The following is a description of a gene set: Human Gene Set: GSE45365_HEALTHY_VS_MCMV_INFECTION_CD8_TCELL_IFNAR_KO_UP Genes up-regulated during primary acute viral infection in dendritic cells with IFNAR1 knockout: CD8A versus ITGAM+. studied in species Homo sapiens Murine Cytomegalovirus (MCMV) infection leads to early activation of various immune cells, including B and T lymphocytes, before the actual initiation of antigen-specific adaptive immunity. This activation is partly driven by innate cytokines, including type I interferon (IFN), which are induced early after infection. The objective of this study was to address the role of type I IFN in shaping early/innate B and T cell responses to a primary acute viral infection. In order to decipher the specific impact of IFN-I on cell subsets, we performed a genome-wide expression analysis on WT splenic B and CD8 T lymphocytes isolated from C57BL/6 mixed bone marrow chimera mice. This study complements series GSE39555, which focused on early responses of NK cells and of the two subsets of conventional dendritic cells., and this is the list of marker genes: C20orf204, ZNF295-AS1, SESTD1, PROP1, A4GNT, AFF1, IQCM, LINC00205, CNTN1, ZNF461, SLC9B2, KCNQ1DN, TPSAB1, IPO5P1, SUPT20H, TRIM73, GFOD1 (Gfo/Idh/MocA-like oxidoreductase domain containing 1), ZNF695, RIGI, ERGIC2, FAM53A, ZNF397, LINC02026, TMEM107, CATSPERG, NEUROG1, NDP, KCNK12, SMIM7, GPR180, NFKBIZ, KDM2A, FGD4, RNFT1, CENPL, ASCL1, AANAT, WDR49, NR1D2 (NCBI Gene Id 9975), KCNK1, SEMG2, LRRC63, TBX6, COL27A1, AGPAT5, H4C8, TMEM50B, DIABLO, PPIL4, EOGT, DHRS7B, ZNF830, SLC2A10, NBPF8, ALOXE3 (arachidonate epidermal lipoxygenase 3), NFE2, BEST4, SMR3A, NEK1, TMEM51-AS1, GABRB3, H2BC5, RPL23AP32, LILRA2, THSD4, BAZ2B-AS1, LNPK, CBLC, DNAJB14, HERC2, MRPL32, DOK2, DSN1, EPPIN, TMEM101, PPP4R3B (NCBI Gene Id 57223), FAM27E3, SLC4A7, CCL7, LINC00907, TMEM207, CENPM, TUBE1, PNPLA3, PLAAT4, DOK6, KCNQ5, QRFPR, CDHR3, CRY1, GLA, PHLDA1, DRC12, TSPAN31, APOC3, ABCC6, SLC39A2, IQCC, FABP3, PAQR3, SYNC, AMOTL2, HPS1 (HPS1 biogenesis of lysosomal organelles complex 3 subunit 1), RAPGEF4, CNBD2, LTO1, ZNF844, CFAP44, NDUFA4L2, UNC50, CRIM1-DT, HRH3, JPH2, TNFRSF14, ULK4, CRYGS (NCBI Gene Id 1427), S100Z, ZNF496, DUSP19, ZC3H12A, ZNF214, RAD1 (RAD1 checkpoint DNA exonuclease), CEBPE, HFM1, H3C10, ZNF114, CCDC15, NEUROD4, ENPP4, CAMKK2, SYS1, PRTN3, EVPLL, TTC28, TRIM69, TFAM, NR2E1, TMEM87B, RXFP3 (NCBI Gene Id 51289), OR1A1, EDNRB (NCBI Gene Id 3282), RAP2C, ARHGAP32, LRRC56, FFAR1, VN1R5, TOB1, CFAP96, CST9, ZNF565, RASGRP4, ADAM8, NOL3, FES, ENSG00000291211, GUSBP2, ZNF682, ITGB8, H2AC6, CROT, ARHGAP22, CALCRL, HOXB3 (homeobox B3), DUT (deoxyuridine triphosphatase), DPT, ELMOD1, PXDC1, UBASH3A, LPIN3, TMEM260, RBM41, C2CD2, MBD4, TENT5B, EOLA1-DT, ZNF780B, SNORA71B, WNT5A, NXNL1, RAMP2-AS1 (NCBI Gene Id 100190938), RFPL2, F11, TRPC4, XCR1, CIMAP1D, GRM2, FSTL3, OR2C3, TOP1, FLT3, ENSG00000187186 (novel protein)